The following is a description of a gene set: Furin is a proprotein convertase induced in activated T cells, reported to processes the anti-inflammatory cytokine TGFb-1. Herein, we show that conditional deletion of furin in T cells allowed for normal T cell development but impaired the function of regulatory T cells and effector cells, which produced less TGFb-1. Furin-deficient Treg cells, were less protective in a T cell transfer colitis model and failed to induce Foxp3 in normal T cells. Furin-deficient effector cells were inherently overly active and were resistant to suppressive activity of wild-type Tregs. Thus, our results indicate that furin is indispensable in maintaining peripheral tolerance, which is due, at least in part, to its nonredundant, essential function in regulating TGFb-1 production. Targeting furin has emerged as a strategy in malignant and infectious disease. The current work suggests that inhibiting furin might activate immune responses, but may result in a breakdown in peripheral tolerance. from publication Pesu M, Watford WT, Wei L, Xu L, Fuss I, Strober W, Andersson J, Shevach EM, Quezado M, Bouladoux N, Roebroek A, Belkaid Y, Creemers J, O'Shea JJ (PMID 18701887) studied in species Homo sapiens Genes down-regulated in naïve wildtype CD4 T cells versus those from T cell specific FURIN knockout mice. Human Gene Set: GSE11884_WT_VS_FURIN_KO_NAIVE_CD4_TCELL_DN, and this is the list of marker genes: DHX34, ADCY2, LINGO4, DPYSL4, TBC1D22B, EGLN2, TIMM23, STK31, MYB (NCBI Gene Id 4602), GZMM, SPAG9, MPIG6B, SCARB2, BTBD2, PDE6B, POLR2A, LCE3A, CD48, FBXO10, GPR151, LPIN1, MPO, GUSB, NAMPT, CASP8AP2, CATSPERD, CD207 (CD207 molecule), PITPNM2, IRX3 (NCBI Gene Id 79191), MIR129-1, MEX3D, DCTN1, LRRC4, PCDHB2, WNK1, ZXDC, TAFA3, SPESP1, SLC16A7, FPGT, STRA8, CEP57, GEN1, TRADD, WEE1, QRFP, PXMP4, SLC25A30, CCDC60, LYSMD2, PPP4R1, RANBP10, HRH2, RPRD1A, ABCA7, MRPS21, MFSD11, UCKL1, C1QTNF6, DST, ZMYND12, HOXC8 (NCBI Gene Id 3224), EIF4E1B, SLC43A2, LEAP2, PMPCA, TIGD2, RPRD2, METRNL, SPAST, SLC29A2, MFHAS1, TMEFF1, OMA1, SLC30A3, TMEM14C, RCBTB2, ACTR6 (actin related protein 6), GSTM1, PPWD1, CMAHP, MRGPRD, ALDH3B1 (NCBI Gene Id 221), TOB2, KEAP1, ZIC3, FOXO3, GUCY1B1 (guanylate cyclase 1 soluble subunit beta 1), BCL2L2, ACKR2, UBN1, TCP11, FBLIM1, PDLIM4, ETV3L, UBE3D, PPM1L, B4GALT5, USP2, ALG9, IQGAP1, RAB17, EEIG2, CCDC51 (NCBI Gene Id 79714), FHIP2B, PTGER3, RNF151, ABCA3, CLCA4, CSTL1, BDKRB2, MLXIP, HAS1, NELFB, HDDC2, TIMELESS, SBNO2, TMOD4, RWDD1, CSRNP2, LRATD2, PRRG1, DGKD, CSN1S1, SEC14L1, TRPV2, ADGRL4, FERMT3